Given this list of marker genes ERGIC2, TMEM201, EPB41L5, BTN2A2, ZNF732, WIPF1, ZXDC (ZXD family zinc finger C), C10orf105, FRMPD1, CCDC15, LRRC10B, PHF13, CSRNP1, NCOR1, SLC13A3, MATR3, DPYSL3, SLC25A44, INSYN2B, PITPNM3, KRT1, PI4KB, SYNPO2, TSGA10, TMEM101, SLC35C1, MYO18A, BPIFB2, NAA20, ASB7, TTPAL, ANAPC11, PBX1 (NCBI Gene Id 5087), GIPC3, ARID1A, CDCA8, FAM168A, CS, THRB, PRORP, PSIP1, NKD1, LHX6, E2F7 (E2F transcription factor 7), MAPRE1, NR2C2AP, RAB8A, LZTS1, WDR33, KCNK10, PRMT5, ZKSCAN1, CFAP53, NTMT1, PRIMA1, IP6K2, SV2B, MKRN1, KCNB1, MINDY1, LILRB4, OAS1, DDX42, PRX, BTBD7, OLIG2, MARCKSL1, TENT4A, DCLRE1C, TRIP13, APTX, MITF, ASTN1, ELK1, GPSM3, AMER1, LRRC20 (NCBI Gene Id 55242), PROM2, WAPL, ARHGEF40, STARD13, KLHL12, LINC03040, PAK1IP1, SLC25A36, CAPZB, DIAPH1, ADGRF2P, TGFA, PKLR (pyruvate kinase L/R), GALNT12, SLC2A1, AFG1L, TET3, CLIP3, KIF18A, here is a description of the gene set: Human Gene Set: MIR1266_5P from publication Chen Y, Wang X (PMID 31504780) species: Homo sapiens Genes predicted to be targets of miRBase v22 microRNA hsa-miR-1266-5p in miRDB v6.0 with MirTarget v4 prediction scores > 80 (high confidence targets).